The following is a description of a gene set: In the body, aspirin (acetylsalicylic acid) is hydrolyzed to salicylate (ST). ST can then be hydroxylated to yield gentisic acid, conjugated with glucuronate, or conjugated with glycine to yield molecules that are excreted by the kidneys. The third of these conjugation processes is annotated here. It is the major route of ST catabolism and accounts for 20–65% of the products. The conjugation proceeds in two steps. First, ST and ATP react with coenzyme A to form salicylate-CoA (ST-CoA), AMP, and pyrophosphate in a reaction catalyzed by xenobiotic/medium-chain fatty acid:CoA ligase. Second, ST-CoA and glycine react to form salicyluric acid and Coenzyme A. part of: Conjugation of carboxylic acids Reactome Pathway: Conjugation of salicylate with glycine studied in species Homo sapiens, and this is the list of marker genes: ACSM5, ACSM4, GLYATL3, GLYATL2 (glycine-N-acyltransferase like 2), ACSM2B, ACSM2A (acyl-CoA synthetase medium chain family member 2A), GLYAT, GLYATL1